The following is a description of a gene set: studied in species Homo sapiens Binding to a small regulatory RNA, a short RNA (usually 50-200 nt long) that is either independently transcribed or processed from a longer RNA by an RNAse enzyme. Human Gene Set: GOMF_REGULATORY_RNA_BINDING, and this is the list of marker genes: MATR3, LINC-ROR, YBX1, SOCS3, POU5F1, ZC3H12A, PNPT1, DICER1, RBM10, SOX2, TEX19, CNOT7, PIWIL3, PIWIL2, TLR9, HOTTIP, DDX21 (NCBI Gene Id 9188), NEAT1, PUM2, TARBP2, RC3H1, MALAT1, OIP5-AS1, TLR7, HNRNPU, TUT7, MECP2, DHX9, AGO4, HNRNPA1, DNM3OS, AGO1, FMR1, SOX4, ARB2A, RBM4, PRKRA, MBD2 (methyl-CpG binding domain protein 2), AGO2, ZNF346, SPOUT1, DND1, ZC3H7B, PIWIL1, SMAD5-AS1, QKI, PIWIL4, LIN28A, ARB2BP, TRIM71, TUSC8, ZC3H7A, ZC3H10, XIST (NCBI Gene Id 7503), ELAVL1, AGO3, PUM1, HNRNPA2B1, TUT4, ZNF697